The following is a description of a gene set: Genes containing one or more binding sites for (Klf6) in their promoter regions (TSS -1000,+100 bp) as identified by GTRD version 20.06 ChIP-seq harmonization. from publication Yevshin I, Sharipov R, Kolmykov S, Kondrakhin Y, Kolpakov F (PMID 30445619) species: Mus musculus Mouse Gene Set: KLF6_TARGET_GENES, and this is the list of marker genes: Or6c3b, Nceh1, Arf2, Akp3, Hfm1 (HFM1, ATP-dependent DNA helicase homolog), Gm4889 (NCBI Gene Id 234159), Fat2, Vmn1r-ps29, Or5d46, C630050I24Rik, Pex1, Gm24292, Kirrel3, Gm11203, Or14c46, Gm43217, Phykpl, Lrrc4c, S100a8, Entrep2, Itpka, Or6c70, Kazn, Gm26020, Or5ak25, Gm34732, Pagr1a, 1700020L24Rik, Foxp1, Wars2, Or51k4-ps1, Pak3, Usp22, Gm16372, Gm12538, Astl, Cnpy4, Slc25a12, Map4, Gm5703, Trim6, Mrgprb1, Or8b55, Adgrl1, Gm8055, Dipk2b, Nutm1, Gm10730, Wdr17, Tpd52l1, Gm26684, Keap1, Slc9b1 (solute carrier family 9, subfamily B (NHA1, cation proton antiporter 1), member 1), Ddx59, Cmbl, Gm14856, Rit2, Ociad1, Hmgb1, Vmn2r27, Kif2a, Gm12011, Pigbos1, Sel1l3, Gm38137, C030034L19Rik, Tex14, Map3k7, Zfp825, Pls1, Accsl, Plscr1, Prox1 (prospero homeobox 1), Enpp5 (ectonucleotide pyrophosphatase/phosphodiesterase 5), Adamts17, Gm12860, Vmn2r71, Ddb2, Prmt3, Or5d38, Gm6621, Mir223hg, Zfp110, Asb2, Gm5805, Rbm33, Atp5po, Helq (helicase, POLQ-like), Osbpl8, Rpl24, Gjd3, Zfp961, Gm25672, Pknox1, Gm12579, Cspp1 (NCBI Gene Id 72327), Cfh, Or6b9, V1rd19, Gm17213, Tas2r109, Rps27a, Ripk3, Adcy2, Gm6912, Gm7805, Rgs1, Gm15934 (NCBI Gene Id 102638854), Pla2g2d, 1700018A23Rik, Gm14907, n-R5s194, Rps11-ps4, Myt1, Gm12353, Cdh7, Or7e173, Ighv2-8, Prss46, Rpia, Ccdc170, Usp7, Rpl23a-ps4, Gm4895, Or14c41, Bricd5, Tenm3, Nagk, Taf6, Cbs, Elovl7, BC002059, 4930519A11Rik, Hnrnph3, Gm23231, Zfp609, Plp1, Ighv1-42, Dnah12, Efcab7, Ash1l, Agtr2, Erlec1, Fgb, Kcnj16, D3Ertd751e, Gm10364, Ptdss2, Gm8666, Tnnt1, Rasa3, Uqcrc1, Strn4, Gm23032, Ugp2, Zfp207, Bst1, Rnpc3, mt-Tp, Klhl6, Trbc1, Cd164, Zfp267, Or2y1f, Or6c76b, Mbnl3, Tfec, Elk3, Mir6951, Parp11, Gm5224, Dydc2, Gm24764, Sdr9c7, Ergic2, Gm6067, Natd1, Srgap2, Efcab9, Cntln, Or8b51, Psmd6 (proteasome (prosome, macropain) 26S subunit, non-ATPase, 6), Alpl, Gm7816, Prrt2, Gm5590, Mpdz, Gm26088, 6030443J06Rik, Exoc4, Sppl3, Tmem165, Tpr, Gm12770, Casp4, Acsm1, Nedd4, Mdm4-ps, Gm11919, Nup88, Dlc1, Borcs6 (NCBI Gene Id 71923), 2310002F09Rik, Eda, Or4a74, Rangap1, Gm15794, Traj3, Svopl, Gm8087, Tmem87b, Adam29, Ank3, Mir708, Ralgapa2 (NCBI Gene Id 381383), Hook1, 1700031L13Rik, Clec4a2, Acsm3, Vmn1r224, Cdon, Chd8, Cep135, B3glct, Gm25117, Cd200r4, 2010204K13Rik, Spmip7, Aldh9a1, Pomt1, Ntm, C030014I23Rik, Mir6354, A230072E10Rik (RIKEN cDNA A230072E10 gene), Gm12401, Ppfibp1, Tob2, Gm15860, Gm34303, Pcgf3, Ibsp, Ttll5, Gm15564, Gnptab, Slc40a1, Or9b1-ps1, Adcy1, Sema4d, Gm25764, Vmn2r59, Gm25857, Eml5, Gm8325, Mir6236, Cip2a, Ophn1, Ighv3-6, Uspl1, Mir30c-2, Commd8, Ezh2, Commd1, Nobox, Gm24965, EU599041, Cpne4, Cep170, Mideas, Nrk, Mapk10, Gm25390, Or5k1, Arap1, Phip (NCBI Gene Id 83946), Gm24202, Or1e27-ps1, Cacnb2, Gm14576, Etaa1, Maml2, Mm2pr, Or9c1-ps1, Cldn23, Gm25261, Rps15a-ps1, Zfp53, Etaa1os, Lrp1, Ptprv, Or7c74, Gm13758, Gm18747, Efr3a, 5530601H04Rik, Gm24553, Ubap2, Nrbp1, Vmn1r-ps23, Gm4660, Or8g2b, Gm26425 (predicted gene, 26425), Ints12, Arid4b, Aste1